Given this list of marker genes SLC22A5, ACY1, COG8, MYRF, GCDH, ATP5F1A, PCCB, SLC25A15, RANBP2, NAGS, MPV17, NDUFS4, SQOR, FBP1 (NCBI Gene Id 2203), PCCA, TRAF3, HMGCL, here is a description of the gene set: Acute encephalopathy Human Gene Set: HP_ACUTE_ENCEPHALOPATHY species: Homo sapiens